The following is a description of a gene set: Genes having at least one occurrence of the motif MKVATTTGCATATT in the regions spanning 4 kb centered on their transcription starting sites. This matches the POU2F1 transcription factor binding site V$OCT1_05 (v7.4 TRANSFAC). species: Homo sapiens Human Gene Set: OCT1_05, and this is the list of marker genes: ZFP36L1, MID1, HOXB1 (NCBI Gene Id 3211), PI4KB, SH3GL3, GCM1, IL6, ADORA1, CRH, GSC, DPYSL3, ARHGAP4, PRDM10, ASCL3, GALNT1, DCAF17, BHLHE22, SPATA31H1, GADD45G, EBF1, OR8B8, ATP2A2, TRPM1, OR10J1, SEC22A, IL25, NKX2-1, RFTN2 (raftlin family member 2), ADGRL1, PIM1, FGF20, NUDT3, GRIA3, PARP6, HOXA3, COL12A1, SMPX, RHOBTB3, ZHX2 (zinc fingers and homeoboxes 2), POU2F1, ENPP1, NEIL3, TMSB4XP4, PMEL, ZNF271P, ZNF428, PROKR2, DCN, DLX1, CAMKV, RPP21, HOXA5, YWHAB, CPA4, EIF3J, EGR2, LRRN3, TRERF1, MAML3, PPM1E, NEDD9, HOXB3, MRAS, ING1, TREX2, SLC6A15, CES5A, VPREB3, HOXD11, ARHGEF38, SLC39A13, IL1RAPL1, SP6, PRKCB, THRA, PPP2R3A, RHOBTB1, SOST, TCF12, SCNN1A, BTK, CDK2, ARMC6, JCHAIN, TBR1, LPL, LRRN1, IMPG2, VGLL3, RARB, MANF (mesencephalic astrocyte derived neurotrophic factor), TAAR1, GPRC5B, CRACR2B (calcium release activated channel regulator 2B), ADNP2 (ADNP homeobox 2), PROM1, NRL, LCOR, CDX1, SOX5 (SRY-box transcription factor 5), MAP2K6 (mitogen-activated protein kinase kinase 6), NR4A3, FOXP2, ALDH5A1, SLIT3, CADM2 (NCBI Gene Id 253559), CNNM4, H2AC20, IKZF2, CTNND1, CDCA7, GNA14, TAS2R40, MAB21L3, TMOD2, EHF, PHOX2B, DUSP6, FGF14, DGKG, ZNF485, TOPBP1, METTL8, ARMCX4, GGNBP2, PRR34, SATB2, STMN2, LHX6, SLC7A11, FZD4, LRMDA, HOXB2, SUGP2, LMO3, COL25A1, ADNP, PLEKHA6, RHOB, IRX2, TBXAS1, CEP41, PDE4D, HIVEP3, CEP120, ARAP2, PANK4, CDX4, MIR17HG, KCNN3, H2AC6, ISL1, HMGB1, GPM6A (NCBI Gene Id 2823), RNF38 (NCBI Gene Id 64796), BCL2, IRX2-DT, AMBN, GRHL3, NOL4L, PRRX1, STAT4 (signal transducer and activator of transcription 4), RGS3, ACYP2, FGFR2, CSN1S1, NR2E1, PKNOX2, TCF7L1, NIN, ESRRG, TMSB4XP6, DMD, TMSB4XP8, MYBPC1, ELK3, NOS1, REM2, CTAGE4, PAX6, SLC9A7, H2BC26, TFAP4, SLC19A3, CDX2, NFYB, LGI1, UBE3A, LIG4, LDB2, SCML4, ROGDI, CPNE1, MYH1, PARP8, PCDH8, FOXK2, MTUS1, LINC01138, DENND1B, RRAS, HOXA10, BARHL2, ITCH, SIX1, LINC01567, HOXB9, HOXC11, C2CD5, LYN, SVIL, PLPPR2, HNF1B, KRT18P55, PRDM12, FOS, RGS13, ITPR3, NRP2, HOXC5, CD40LG, KCNT2, FSTL5, PTEN, ZBTB20, PIM2, LRFN5, KRTAP8-1, ZBTB18, TLL2, SERTAD4, ZNF423, FEZF2, SEMA6C, TSPAN13, CSRNP3, CADM1, POU2F3, SCML1, SEMA7A, PURA, EMILIN3, NEUROG1, H2AC25, COLCA1, SYT1, EDN1, DKK1, SKIDA1, PTPN2 (NCBI Gene Id 5771), GABRB1, BNC2, CNMD, LPP, DTNA